The following is a description of a gene set: Catalysis of the reaction: acetyl-CoA + histone H4 L-lysine (position 16) = CoA + histone H4 N6-acetyl-L-lysine (position 16). This reaction represents the addition of an acetyl group to the lysine at position 16 of histone H4. Mouse Gene Set: GOMF_HISTONE_H4K16_ACETYLTRANSFERASE_ACTIVITY species: Mus musculus, and this is the list of marker genes: Jade2, Ncoa1, Ep300, Kat6a, Kat7, Naa60, Kat6b, Clock, Kat5, Nat8f7, Taf1, Gtf2b, Gtf3c4, Ing4, Ing3 (NCBI Gene Id 71777), Crebbp, Kat2b, Jade1, Mcm3ap, Kat8, Cdyl, Kat2a, Nat8f3, Ncoa3, Hat1